Given this list of marker genes SOAT2, PHF10, KRR1, PTPRS, PDE6A, WT1, NXPE3, H3C6, ZNF133, ZNF157, CLOCK, IL16, PLEKHB1, IVL, IGKV7-3, SERPINA4, RXRG, PGM3, MFN1, ITIH3, PHOX2B, GPR19, SLC17A1, FIG4, GRIP2, NEB (NCBI Gene Id 4755), OPRL1, FGF18, GHRHR, P2RY10, ADAM20, STARD5, CPZ, HTR7, CPB2, RREB1, SLC6A11, WBP4, PSG1, DPT, TBC1D22A, EPHB2, ADCYAP1, RORB, ELL2, POU6F2, KANK3, ZBTB40, ERC1, GRIK1, NF1 (neurofibromin 1), PRPS1L1, JRKL, PAX6, TNK1, RAD51D, DRC3, CCR3, CD6, SULT4A1, HTR3A, KCNA5, IL7, ZNF202, SLC15A1, ADAMTSL3, GCM1, ERCC4, GABRB2, ZBTB14, SLC6A2, PPP1R1A, EDIL3, SLC17A3, TSSK2, CAMK2G, SLC18A1, AOC4P, MLN, BRD4, ARFGEF2 (ADP ribosylation factor guanine nucleotide exchange factor 2), MON2, PIK3C2A, AQP5, IL11RA, KRT33A, SLC30A3, JADE3, AQP7, HOXD4, PIGB, CAMK4, KLHL18, SYNJ2, CADM4, IFNA14, GJB5, SPA17, AKAP3, TBX19, HNF1A, FNTB, BARX2, SLC4A3, KRT1, SRPK3, MAGEA9, HABP4 (NCBI Gene Id 22927), PPP2R5B, SLC13A2, UBE4B, PART1, NR1I2, LILRA1 (NCBI Gene Id 11024), STK17A, BNIP1, LECT2, S100A5, IL13, NRTN, MPZL1, KRT33B, PCM1, IPO9, MAGEA8, FOSL1, IL4, FSHR, TIE1 (tyrosine kinase with immunoglobulin like and EGF like domains 1), NCKIPSD, MYT1, RUNX2, MAGI1 (NCBI Gene Id 9223), FLT1, ATP10B, SLC16A5, TBXT, MC5R, SIX3, CTRL, MYO9B, HTR4, MYH2, CYP11A1, MLLT10, TTTY1, PVR, MSL3, RSC1A1, SUPT3H, KRT86, PDE4D, STAC, CMKLR2, PPP1R12B, ESR1, POFUT2, ATP8A2, TGFBR1, MSX1 (msh homeobox 1), FZD5, ZSCAN26, FRYL, ZNF132, TNIK, TRIM24, KLRC4, NTNG2, PAX9, C1orf216 (chromosome 1 open reading frame 216), PIK3CB, NPFF, CEP162, CYP2D6, ATP4B, MAP2, GNG4, ABO, MYOZ3, TENM4, SLC22A6, TFDP2, RBMXL1, PAXIP1 (PAX interacting protein 1), CHST1, BRCA1, CALN1, ZNF592, HTR1E, RPS6KA5, MSH3, USP20, PSD, RB1CC1, GPR171, TNFRSF25, TMEM26, ARL3, ATF2, AMMECR1, ABCB9, COL19A1, SIM2, DGCR5, COX6A2, LILRA4, OR2B6, POLR2K, JRK, ATP6V0A2, TRIO, ATXN3, ABCB1, DAPK2, HCRTR2, PHLDB1, BRINP3, POU6F1, TACC2, MDM2, FUT6, B4GALT6, LTBP4, COL8A1, TANC2, NR3C2, PRELID3A, LPGAT1, FAS, PLPPR4, CRHR1, ITIH4, RUNX1, NR2F1, NOS2, POLR1HASP, RNF24, ATP2B2, ELAVL2, BCL2L11, NFX1, CDC73, SLC46A3, DNAJC16, CD3E, ZNF500, MPZL2, SCAPER, TMEM11, EXOC4, RYR3, CYP4F2, GPR15, DBT, ZNF200, BCL2, SOCS6, CYP2E1, ZNF134, ATP8B1, GRIK5, ADCY3 (adenylate cyclase 3), BMP10, PLXNA3, GPR18 (G protein-coupled receptor 18), ABCC8, HTR1B, KRT2 (keratin 2), SLC33A1, ABCB10, CFH, SULT2B1, SLC2A1, SYT5, GLE1 (GLE1 RNA export mediator), MC2R, CELA2B, TBX5, AFF2, SIX6, COLQ, MINDY2, CASP10, MGA, COLGALT2, PAX7, GPATCH8, NTPCR, here is a description of the gene set: Human Gene Set: MORF_NOS2A species: Homo sapiens Neighborhood of NOS2A Neighborhood of NOS2A nitric oxide synthase 2A (inducible, hepatocytes) in the MORF expression compendium